Given this list of marker genes CCND3, XPNPEP3, CKS1B, LINC01127, HSD11B2, STIP1, MTFR1L, ACAA1, CKS2, HSPD1, PGAM5, HSPE1-MOB4, UBQLN1-AS1, HIKESHI, HMGB1, DNAJB6, RAP2A, RNA5SP473, RAB5IF, HSPA1L, RNF157-AS1, ESRRA, CHORDC1, HSPH1, CRYZ, NRSN2-AS1, HSPA1B, NRSN2, ELL, MRPS6, MED9, CACYBP, PTGES3, ALB, UBQLN1, TSR2, CCT3, TSACC, MRPL18, VIPAS39, TYW3, SERPINH1 (serpin family H member 1), NOP58, BAG3, AHSA1, DDX39B-AS1, ZFAND2A, SLC25A6, FKBP4, ZNF227, SHC1 (NCBI Gene Id 6464), MVB12A, HPD, PWWP3A, HSP90AA1 (heat shock protein 90 alpha family class A member 1), ZNF497, CBX3P4, KAT2A (NCBI Gene Id 2648), HSPE1, KRBA2, ALAS1, FBXO15, LINC02324, FEM1B, UBOX5, CYP4F12, APTX, MIR4258, FASTKD5 (NCBI Gene Id 60493), CSTPP1, HSPA8, HSP90AB1, IL32, MGST2, COMMD1, HSPA1A, MORC4 (MORC family CW-type zinc finger 4), TEKT1, ENSG00000267248, LINC02159, BISPR, MRPL15, TCP1, HSPB9, CCDC117, ZFAND2A-DT, ST13, SLC5A3, DDX39B, PCBD1, ATP5MC3, CTSH, GTF3C3, CCT4, USPL1, BST2, UBB, TIMM21, FOXJ1, DNASE1, DNAJA1, here is a description of the gene set: Human Gene Set: PPARGC1A_TARGET_GENES from publication Yevshin I, Sharipov R, Kolmykov S, Kondrakhin Y, Kolpakov F (PMID 30445619) studied in species Homo sapiens Genes containing one or more binding sites for (PPARGC1A) in their promoter regions (TSS -1000,+100 bp) as identified by GTRD version 20.06 ChIP-seq harmonization.